Given this list of marker genes PRPF6, KCNK3, VDAC2, RPL9P7, EIF3F, CRY2, RPL23A, AIMP2, BCR, FLRT1, RBM4B, ABCC8, RPS13, PPIF, ZMIZ1, ELMO1, ASIC1, UQCRB, RPL30, RPL36AL, RPL24, GATD3, API5, PDHX, YIF1A, RPL27A, RPL4, EIF3E, RPS20, TMEM97, TNR, ANGPTL2, OLIG2, AFAP1, APC2, POLR2F, ID1, RPLP2, RPS6, CIRBP, HIP1R, PDE8B, GRIK2, PFKM, NCAM1, TNK2, here is a description of the gene set: Top 50 marker genes for anaplastic oligodendroglioma (AO), a class of high grade glioma. from publication Nutt CL, Mani DR, Betensky RA, Tamayo P, Cairncross JG, Ladd C, Pohl U, Hartmann C, McLaughlin ME, Batchelor TT, Black PM, von Deimling A, Pomeroy SL, Golub TR, Louis DN (PMID 12670911) Human Gene Set: NUTT_GBM_VS_AO_GLIOMA_DN In modern clinical neuro-oncology, histopathological diagnosis affects therapeutic decisions and prognostic estimation more than any other variable. Among high-grade gliomas, histologically classic glioblastomas and anaplastic oligodendrogliomas follow markedly different clinical courses. Unfortunately, many malignant gliomas are diagnostically challenging; these nonclassic lesions are difficult to classify by histological features, generating considerable interobserver variability and limited diagnostic reproducibility. The resulting tentative pathological diagnoses create significant clinical confusion. We investigated whether gene expression profiling, coupled with class prediction methodology, could be used to classify high-grade gliomas in a manner more objective, explicit, and consistent than standard pathology. Microarray analysis was used to determine the expression of approximately genes in a set of 50 gliomas, 28 glioblastomas and 22 anaplastic oligodendrogliomas. Supervised learning approaches were used to build a two-class prediction model based on a subset of 14 glioblastomas and 7 anaplastic oligodendrogliomas with classic histology. A 20-feature k-nearest neighbor model correctly classified 18 of the 21 classic cases in leave-one-out cross-validation when compared with pathological diagnoses. This model was then used to predict the classification of clinically common, histologically nonclassic samples. When tumors were classified according to pathology, the survival of patients with nonclassic glioblastoma and nonclassic anaplastic oligodendroglioma was not significantly different (P = 0.19). However, class distinctions according to the model were significantly associated with survival outcome (P = 0.05). This class prediction model was capable of classifying high-grade, nonclassic glial tumors objectively and reproducibly. Moreover, the model provided a more accurate predictor of prognosis in these nonclassic lesions than did pathological classification. These data suggest that class prediction models, based on defined molecular profiles, classify diagnostically challenging malignant gliomas in a manner that better correlates with clinical outcome than does standard pathology. studied in species Homo sapiens